Given this list of marker genes STAT5A, NCOA3, FOXP1, PTPRN, HDAC4 (histone deacetylase 4), MTA2, ARID5A, ETS2, PAGR1, OASL, REST, POLR1E, BUD31, NBN, MED14, TRIM24, MAD2L2, RBBP8, UBE2I, HIRA, MED25, PER1, GRHL1, FOXC1, ZNF618, SPI1, NFE4, DDX54, XPC, STAT5B, KDM4C, YY1, TBXT, ASXL1, SETD1A, CREBBP, HEY1, CTBP2, ZNF366, NR4A1, SPEN, HSPB1 (heat shock protein family B (small) member 1), BCL6, RAD23B, PBX1 (PBX homeobox 1), STAT1, CRTC1, CRTC3, TAF12, TAF1B, PITX1, SRY, CNOT7, GTF2A2, MTA1, AR, TRIM68, STK36, PER2, XBP1, SIRT2, MEF2C, ASCL2, TBX2, ZBTB8A, DHX9, SCX, MED1, DMAP1, SMARCA4, PPARD, MDFIC (NCBI Gene Id 29969), EHMT1, LEF1, C1QBP, PSMD10, CREM, SMAD2, TAF1L, HDAC7, MED16, DCAF13, SOST, RFX5, TDG, H2BC9, NEK6, TACC1, SIN3A, RB1, TRIM6, MAPK3 (mitogen-activated protein kinase 3), TGFB1I1, PRDM13, ZFPM1, ZBTB16, GSC, HIF1A, RBPJ, MEF2A, HCFC1, CAND1, CRKL, NLK, DCAF1, ZBTB17 (NCBI Gene Id 7709), NCAPG2, CHD4, BCL3 (NCBI Gene Id 602, BCL3 transcription coactivator), TFDP2, CARM1, ETS1, GATA6, SRARP, KDM5D, TAF13, HDAC1, DNAAF4, NR5A2, TCF4 (transcription factor 4), ZBTB49, NFYB, BBS1, C1D, RARA, PDX1, USF1, MLX, SP3, ASCL1, GATA4, MTDH, CHD6, PHB2, MED13, PARK7, TLE4, USP11, TCF23, BAIAP2, MEIS2, FOXF2, NKX3-1, YEATS2, FHL2, NR3C1, ACTB, NCOR1, FAM220A (family with sequence similarity 220 member A), MKKS, TBK1, TCF21, ASAH1, CAND2, STRN, RUVBL1, TP53BP2, CBX5, FAF1, XPO1, WWP2, FLYWCH1, TADA3, PROX1, NCOA2, TBX6, CXXC5, CRTC2, RFC1, TXLNG, SMARCE1 (SWI/SNF related, matrix associated, actin dependent regulator of chromatin, subfamily e, member 1), RERG, SIK1, JMJD1C, FOXO3, CBX3 (NCBI Gene Id 82756), BTAF1, FLT3, SETD6, ARID1A, RNF6, TBX20, RXRA, HIPK2, RARG, GTF2B, DACT1, KAT8, PPID, CTNNBIP1, VGLL4 (NCBI Gene Id 9686), NR0B2, COMMD8, ID2, FOXO4, LMO2, HEY2, DDIT3, EOMES, NOP58, POU4F1, SLC30A9, TRIP12, CNOT2, TP53BP1, DDX20, GMNN, TCF7L2, LMO4, TFAM, E2F1, KAT6A, GATA1, WFS1, EZH2, HNF4A, HMGB1, TMF1, NKX2-1, THRA, POU1F1, WBP2, RUVBL2, SOX10, SOX9, IFI27, SOX17, CEBPB, RELA, NCOR2, BBS2, STAT6, AHR, PSMD9, PPARGC1B, NR1I2, CTBP1, NFATC1, HDAC9, SMARCA1 (SWI/SNF related, matrix associated, actin dependent regulator of chromatin, subfamily a, member 1), PASD1 (NCBI Gene Id 139135), EPAS1 (NCBI Gene Id 2034), ZNF703, TCF12, GTF2F1, FAM220BP, PARP10, NR0B1, TACC2, FOS, CITED2, HDAC6, GBX2, TPT1, PTPRT, MED30, CALR (calreticulin), ZNHIT3, MED4, RARB, DUSP26, UHRF2, JUND, SRI, VDR, GATA3, HAND1, FOXL2, KCTD1, TAF11, PADI2, TERT, YWHAH, HDAC5, PRRX1, DDX3X, DAZAP2, MAX, NRIP1, PITX2, FBP1, LMO1, CD34, CREB1, TAL1, MAVS, NHLH2, MEF2D, NPM1, TBX5, PPARGC1A, PAX2, PHF1, HMGA1, CHCHD2, MAP3K10, TFDP1, FOXH1, SKI, NR4A3, HMGN3, PRDM5, SMAD4 (SMAD family member 4), NOC2L, JUP, HMGA2, LHX3, ISL1, ATF2, FOXP2, TAF10, COMMD6, TAF4, SIX3, BRMS1, WIPI1, BRF1, DGKQ, RNF14, ESR1, THAP7, PGR, PKN1, IFI16, NCOA1, NR5A1, HOXA7, DOT1L, TLE1, BHLHE41, VHL, ELK1, EN2, GTF2E2, ZBTB43, CDKN2A (cyclin dependent kinase inhibitor 2A), HMGB2, DLL1, MED12, ANKRD2, FBL, NFKBIA, EGR2 (early growth response 2), TWIST1, NR1H4, EHMT2, TEAD3, CIT, NCOA6, KLF4, NSD1, HDAC11, SIRT1, NKX2-5 (NK2 homeobox 5), CTDP1, CRY2, CPNE1, NIF3L1, DNAJA1, MAGEA2B, TRERF1, ERCC1, NFE2L2, RPL23, BCL2, HES6, TAF1, PPARG, ZNF644, EED, FIZ1, IGHMBP2, LCOR, ZNF653, TP73, LRIF1, TBX3, GABARAPL1, RUNX3, UBXN7, TP53, RUNX1T1, PCNA, ELOC, MED6, MYC, LATS1, TRIB2, HIF1AN, ANKRD42 (ankyrin repeat domain 42), INTS13, BMAL1, MYOCD, MIXL1, COMMD7, BBS7, BHLHE40, GATA2, TFCP2, SIX1, TCF15, HAND2 (NCBI Gene Id 9464), NKX6-1, BBS5, MAGEA2, CEBPA, CREB3, E4F1, HCLS1, PHF12, PDCD11, MTF2, CCNT1, DDX5, DTX3L, ADD1, NAAA, NLRP3, HHEX, PBXIP1, TEAD2, GTF2H1, TRIB1, WIZ, LMO3, PPARA, METTL23, PIAS2, CRY1, GTF2A1, TRAPPC2B (NCBI Gene Id 51587), SMAD3, PRDM16, FOXP3, ACTN4, TRIM32, PER3, SOX8, PBX2, MED24, PRKCB, HOXC13, ESRRB, TRIP6, RUNX2, TRIP4, THRB, NCOA7, RNF25, LYAR, CCNT2, TFDP3, FAM89B, SUMO1P1, HDAC3, MAP3K7, EEF1D, BCAS3, CEBPG, STAT3, TCF3, SMARCD3 (SWI/SNF related, matrix associated, actin dependent regulator of chromatin, subfamily d, member 3), NR4A2, KDM1A, ATOH8, HSF1, CDK9, CRX, ZNF516, POU5F1, CNOT1, RBX1, SYVN1, TCERG1, PSIP1, ARNT2, EBF4, BRF2, TAF4B (TATA-box binding protein associated factor 4b), ANKRD1, PIAS1 (NCBI Gene Id 8695), SMARCB1, GSK3B, DRAP1, AKAP8, SRF, DACT2, EIF4E, BEX1, CTCF, SREBF1, ATF7, ZMYND8, BCL10, NOTCH2 (NCBI Gene Id 55574), MAPK14, CSNK2B, CTNNB1, TAF9, ENO1, CIITA, KDM3A, GFI1B, PTMA, KAT5 (NCBI Gene Id 10524), DAXX, SNW1, HDAC2, TCP10L, KAT2A, FLNA, TBP, TAF6, ZBTB7A, MED17, BBS4, NR1D1, SDR16C5, RAD21, GTF2I (NCBI Gene Id 90875), JUN, PURA, NR1H2, DNAJA3, STK4, FKBP4, PRMT2, TTC8, PSMC5, ERCC4, PAX6, PIM1, ZNHIT6, EXOSC9, MMS19, SP1, CGGBP1, MLXIPL, YWHAZ, CDK5RAP3, TAF7, DR1, NUCKS1, PURB, THRAP3, RUNX1, KAT2B, USF2, HDAC8, HNRNPU, MTOR, ID3, CENPF, KEAP1, SP100, DNMT3A, RPS3, RBFOX2, LDB1, PSMA6, GRHL2, DAPK3, PTPN2, ATF4, EDF1, ELOB, STING1, BCOR, SUZ12, RORA, NR3C2, PRKDC, HNF1B, NEUROD1, PARP9, SETD3 (NCBI Gene Id 84193), NFKB1, BRD8, SUMO1, HES1, KLF5, FOXA2, IRX5, AIP, BDP1, IKZF4, FIGLA, ZFPM2, TOB2, YAP1, EP300, ANXA4, PRAME, ARNT, HDGF, BAZ2A, NFIA, BBS10, DHX33, CCDC62, BCL11A (NCBI Gene Id 55085), PARP1, ID4, MYOD1 (myogenic differentiation 1), here is a description of the gene set: Human Gene Set: GOMF_TRANSCRIPTION_FACTOR_BINDING Binding to a transcription factor, a protein required to initiate or regulate transcription. studied in species Homo sapiens